Given this list of marker genes OSR1, RACK1, LHX1, OTX2, TENM4 (NCBI Gene Id 26011), FOXA2, SCX, here is a description of the gene set: Any process that activates or increases the frequency, rate or extent of gastrulation. studied in species Homo sapiens Human Gene Set: GOBP_POSITIVE_REGULATION_OF_GASTRULATION